Given this list of marker genes Arid1b (NCBI Gene Id 78879), Nlgn1, Phtf2, Phlpp2, Nfyc, Rnf4, Cog3, Snx13, Fancm, Daam1, Kifap3, Gata6, Cpeb4, Pcgf3 (NCBI Gene Id 69587), Cic, Ddx3y, Eomes, Cdk16, Ugp2, Grhl1, Chia1, Ube2w (NCBI Gene Id 66799), Atxn3, Osbpl8, Dock9, Gramd2b, D16Ertd472e, Arf1, Zfp287, Mia3, Cldn11, Nsmf, Adcy3, Gnaq, Slc24a3, Cd69, Mpp1, Ppcs, P3h3, Rgs3, Itpr1, Glyr1, Ptprk, Nefm, Sh3pxd2a, Hipk3, Cep41, Aida, Ttc9, Dkk3, Cpeb3, Adamtsl3, Slc38a2, Tmem87a, Fosl2, Ikzf2, Rsbn1, Nox4, Morc3, Gpr180, Trak2, Per2, Asxl2, Gdf11, Hps6, Pkdcc, Bcl11b, Gpc6 (NCBI Gene Id 77735), Grp, Rgs17, Gm5148, Ranbp9, Slc25a36, Sfxn1, Ccnc, P2ry13, Klhl29, Cnep1r1, Edem1, Bcl2l11, Fam20c, Fnip1, Cadm2, Nckap5, Tgif1, Itga6, Ppp1r37, Synj1, Dnaaf9, Fli1, Ddhd1, Wwp2, Itga5, Peak1, Tbl1xr1, Itprid2, Usp28, Acrv1, Luzp1, Lhfpl2, Fcho2, Cyp2d22, Ppp1r12c, Pcdh9, Adamtsl1, Exoc5, Spryd4, Ptpro, Ankrd44, Glra1 (NCBI Gene Id 320836), Fhl2, Avl9 (AVL9 cell migration associated), Ube2z, Gfpt2, Prrc2b, Trio, Sgk3, Golga1, Snapc1, Scn8a, Tsc1, Otud4, Atrx, Adam10, B3galt2, Mast4, Col27a1, B230219D22Rik, Rbpj, Nufip2, Rnf38, Hivep1, Dmxl1, Slc6a1, Sertad3, Tmem184b, Fkbp1a, Syn2, Pcdh7, Kmt5b, Gsta2, Ergic2, Golga4, Ankrd28, Zfp827, Slco6c1, Nsd3, Ptar1 (protein prenyltransferase alpha subunit repeat containing 1), Myo5a, Hecw1, Ccnjl, Dynlt3, Jarid2, Tmem229a, Npc1, Gpr158 (G protein-coupled receptor 158), Gsta5, Man2a1, Wrnip1, Ubash3b, Greb1l, Arrdc4, Col1a2, Hand2, Dcaf6, Galnt14, Lpin1, Baz2b, Myo1b, Foxn2, Pik3cb, Ago3, Slc12a5 (solute carrier family 12, member 5), Cux1, Evi5, Rev3l, Rbm27, Pnisr, Tcf21, Armc1, Zeb2, Fry, Snap29, Bcl11a, Rfx1, Aggf1, 1810055G02Rik, Robo2, Herpud2, Rassf3, Dnajb9, Tulp4, Itgav, Mycbp2, Appl1, Flvcr2, Ddx3x, Bmpr2, Tob2, Zdhhc5, Bahcc1, Sim2, Nsmaf, Prkar1a, Grip2, Adam19, Srpra, Braf, Tpcn1, Pla2g10, Tent4a, Ptger4, Gnpda2, Wasl, Evx2, Dennd1b, Slx4 (SLX4 structure-specific endonuclease subunit homolog (S. cerevisiae)), Herc2 (HECT and RLD domain containing E3 ubiquitin protein ligase 2), Gid4, Klf4, Zfp521, Paxbp1, Glce, Pik3r3, Iqgap2, Bsdc1, Pp2d1, Rab3c, Ldlrad4, Klhl14 (kelch-like 14), Ssbp2, Myt1l, Zfyve21, Cpeb2, Lmbr1l, Prkar2b, Kat2b, Pten, Abhd13, Gata2, Dpp10, Lats2, Nol4l, Ewsr1, Xrn1, Plekhm1, G3bp2, Pcolce2, Fhip2a, Fbn1, Pitpna, Pcdh11x, Dsc2, Arrdc3, Xylt2, Dennd4b, Itga8, Wdfy3, Golga7, Trim36, Bcat2, Sgpp1, Cdca7l, Tbc1d12, Rad21, Slc17a6 (NCBI Gene Id 73055), Rab8b, Btg2, Fnbp4, Fnip2, Robo1, Fmn2, Klf2, Usp36, Slc25a32, Elk4, Dtx2, Insig1, Atxn1, Fbxw7, Tef, Fzd10, Pdzd2 (NCBI Gene Id 75144), Bltp1, Rbpms2, Strn3, Hnf1b, Ric1, Trim65, A830018L16Rik, Sox11, Tob1, Zfc3h1, Med19, Map2k4, Mapk8, Gla, Ddc, Adam23, Dus2, Kcna1, Rhpn2, Isca1, Pip5k1c (NCBI Gene Id 18717), Mboat2, Map1b, Pitpnm2, Atp7a, here is a description of the gene set: from publication Chen Y, Wang X (PMID 31504780) species: Mus musculus Genes predicted to be targets of miRBase v22 microRNA mmu_miR_25_3p in miRDB v6.0 with MirTarget v4 prediction scores > 80 (high confidence targets). Mouse Gene Set: MIR_25_3P